Given this list of marker genes RPL28, TSC22D3, TMSB4X, RHOH, RPL27A, ZNF90, SYNE2, EMB, GZMK, RPS17, SLFN5, BCL11B, SARAF, RPL30, GPR171, RESF1, IKZF3, IL7R, PIK3IP1, RAC2 (NCBI Gene Id 5880), JAML, PCED1B-AS1, RPL13A, PRDM1, TNFAIP8, TOMM7, TRBC2, TXNIP, BTG1, PTGER2, TCF7, RPL39, TC2N, TRAC, RPS3, B2M (beta-2-microglobulin), P2RX5, RPL41, DGKA, PAG1 (NCBI Gene Id 55824), S100A4, PTGER4, RPL21, PTPRCAP, THEMIS, RPS2, CNOT6L, TAGAP, PTPRC, RPL27, RORA, AKNA, RPS25, STK4, RPL18, TRAT1, CD3E, IL2RG, RPL10A, GIMAP7, STK17B, RPS12, ANXA1, ZFP36L2, FYN, RPS27, GATA3, DUSP2, IL32, RPS29, CD44, ADGRE5, RPL34, CLEC2D, LAPTM5, HLA-F (major histocompatibility complex, class I, F), RPSA (ribosomal protein SA), PRF1, CD48 (NCBI Gene Id 962), RUNX2, CD2, SLAMF6, SESN1, FYB1, ERN1, RPL17, LCK, CELF2, BCL2, RPS14, CD3G, RPLP2, LTK, LTB, LCP1, JUNB, SLC4A10, SPOCK2, RPL35A, SIRPG, RPL10, RPS18, RUNX3 (NCBI Gene Id 864), CD52, CAMK4, RPS3A, RPL18A, ETS1, IL18RAP, PDCD4, RPS27A, RPS6KA3, RASGRP1, SATB1, CD96, TRBC1, MDFIC, CXCR6, RPS15A, KLRB1, RPS19, SEMA4D, CD69, GBP5, CD53, SCML4, IKZF1, RPS20, CYTIP, RPL32, TRGC1, INPP4B, ARL4C, CRYBG1, HLA-B, FNBP1, KLRG1, RPL13, GZMA, CD6, ZC3HAV1, SLC38A1, CD40LG, CORO1A, RPL19, CD3D, RPL23A, RPS10, RPS26, CXCR4, RPLP1, MYBL1, PIP4K2A, CD8A, PARP8, TNFAIP3, RPL37, ITK, WIPF1, PBXIP1, SLA (Src like adaptor), ARHGDIB, here is a description of the gene set: from publication Aizarani N, Saviano A, Sagar, Mailly L, Durand S, Herman JS, Pessaux P, Baumert TF, Grün D (PMID 31292543) studied in species Homo sapiens Human Gene Set: AIZARANI_LIVER_C3_NK_NKT_CELLS_2